The following is a description of a gene set: species: Homo sapiens Human Gene Set: REACTOME_THE_ACTIVATION_OF_ARYLSULFATASES The activation of arylsulfatases, and this is the list of marker genes: ARSJ, ARSF, STS, ARSL, ARSB, SUMF1 (NCBI Gene Id 285362), ARSK, ARSD, ARSG, SUMF2, ARSA, ARSI, ARSH